Given this list of marker genes KCNAB2, KRAS, H19, GABRD, GRB10, AKT1, SPEN, TRPV4, ACTB, GNAQ, MNX1, FN1, RERE, SALL1, KAT6A, COL2A1, SATB2, MPV17, SKI, EXT1 (NCBI Gene Id 3966), USP9X, PRKCZ, IDH1, IDH2, SETD5 (NCBI Gene Id 55209), PORCN, TUBB, EBP, TONSL, IGF2, PRDM16, CASZ1, CTSK, DACT1, HSPG2, RASA1 (RAS p21 protein activator 1), PTH1R, DMP1, MAPRE2, PIK3CA, LEMD3, UBE4B, AGGF1, MAPK1, ENPP1 (NCBI Gene Id 5167), PTEN, LUZP1, EXT2, PDPN, MMP23B, here is a description of the gene set: A difference in length or diameter between the left and right leg. Lower limb asymmetry species: Homo sapiens Human Gene Set: HP_LOWER_LIMB_ASYMMETRY